The following is a description of a gene set: from publication Yosef N, Shalek AK, Gaublomme JT, Jin H, Lee Y, Awasthi A, Wu C, Karwacz K, Xiao S, Jorgolli M, Gennert D, Satija R, Shakya A, Lu DY, Trombetta JJ, Pillai MR, Ratcliffe PJ, Coleman ML, Bix M, Tantin D, Park H, Kuchroo VK, Regev A (PMID 23467089) Genes up-regulated in CD4 T helper cells Th17 treated with TGFB1 and IL6: 10h versus 30h. Despite their enormous importance, the molecular circuits that control the differentiation of Th17 cells remain largely unknown. Recent studies have reconstructed regulatory networks in mammalian cells, but have focused on short-term responses and relied on perturbation approaches that cannot be applied to primary T cells. Here, we develop a systematic strategy – combining transcriptional profiling at high temporal resolution, novel computational algorithms, and innovative nanowire-based tools for performing gene perturbations in primary T cells – to derive and experimentally validate a temporal model of the dynamic regulatory network that controls Th17 differentiation. The network is arranged into two self-reinforcing and mutually antagonistic modules that either suppress or promote Th17 differentiation. The two modules contain 12 novel regulators with no previous implication in Th17 differentiation, which may be essential to maintain the appropriate balance of Th17 and other CD4+ T cell subsets. Overall, our study identifies and validates 39 regulatory factors that are embedded within a comprehensive temporal network and identifies novel drug targets and organizational principles for the differentiation of Th17 cells. Human Gene Set: GSE43955_10H_VS_30H_ACT_CD4_TCELL_WITH_TGFB_IL6_UP species: Homo sapiens, and this is the list of marker genes: GAA, CDSN, CD81, BEX4, ORC2, FOXJ1, NEK6, KRTAP13-2, ABCD3, MYOC, GGPS1, SYNGR1, SRP9, NCOR1, KCTD20, ZFTRAF1, H6PD, MTHFR, EXOC7, TOM1L1, SMAD3, IGSF8, CISD1, CPXM1, SORL1, FABP6, CKB, CYP1A1, TAT, GFI1, SAPCD1, PPP1R2P1, GGT5, SHMT2, COPS3, AP1S2, USP18, GDPD3, ARFGAP3, ABCF3, EDN3, TBL1XR1, KIAA0930, MOGS, ZNF692, SOX2, GALNT6, ZFP91, FAM20C, VASP, CSN2, MADCAM1, SPP1, MVK, PPARD, DIO2, ABCA4, TBC1D23, INHBC, ST3GAL1, MKRN2, CBX4, WBP4 (NCBI Gene Id 11193), SLC6A3, ACAD9, FARS2, ATP6V0A1, AQP7, PDPN, JUND, CCL5, BAG2, MEPCE, EIF2D, S100A5, UBE2H, SMARCD1, MXD3, TIGD5, NFKBIZ, CCDC88A, LDB3, MRTO4, RNH1, SLC25A15, PROC, SREBF1, ELAVL3, H3-5, MPZL2, KRT77 (keratin 77), ITGAX, POU2AF1, CFH, SEMA3C, PTGES, WBP11, GP1BA, RAMP2, ZFHX4, MYF6, CCL25, USP22, DESI1, IDS, COL15A1, ARF1, MEIG1, C1QBP (complement C1q binding protein), CSF2RB, ASCC1, CD300C, RBFOX2, AMPD3, MAPK1, COG1, DMD, NPY5R, ENC1, CXCR5, CITED1, C1QB, SEZ6L, HAPSTR1, OPRK1, SLC9B2, TNIP1, PRELID3B, RAD17, YWHAG, TOR1AIP2, ADGRE5, DHFR, GTF2I, RGS8, MRPL40, CD48, SUDS3, CDC45, PGS1, RUNX1T1, PTPN20, AKR1A1, RUNDC3A, CDC42SE1, MRPS18A (mitochondrial ribosomal protein S18A), TRIM21, DPF3, LRP1, CD2AP, F11R, FXR2, TNFRSF4, GRB2, GP1BB, CITED2, CLCN7, CACNA1A, LCP1, RNF5, CYP4A11, UIMC1, EPHX2 (NCBI Gene Id 2053), ADSS1, ISCA2, MRPL17, LDLR, KRTAP8-1, PPIA, RENBP, GCM1, TP53INP2, RFK, RACK1, AP1M1, RYR2, NEUROD4, VPS26A, TUBA4A, AP3S2, SLC25A48, HCCS, OCEL1, NUDT4, STAT6, HRK, GPR65, GBF1, PCSK7, GET3, MGST2, FBP1, ARHGAP45, RASSF5 (NCBI Gene Id 83593), MFN1, POLE2, NDE1, MYH11, SLC38A10, NCOA2